The following is a description of a gene set: species: Homo sapiens Human Gene Set: MIR206 Genes predicted to be targets of miRBase v22 microRNA hsa-miR-206 in miRDB v6.0 with MirTarget v4 prediction scores > 80 (high confidence targets). from publication Chen Y, Wang X (PMID 31504780), and this is the list of marker genes: MEA1, HS3ST3B1, SH3TC2, BCL7A, CLOCK, SLC8A2, NETO2, KMT2E, PPIB, TRA2B, NFATC2, XPO6, KTN1, PLXNA4, CAAP1, SLC25A53 (solute carrier family 25 member 53), RNF138, ZBTB41, PCDHB13, TTC7B (NCBI Gene Id 145567), EIF1AX, FN1, FRS2, TNS3, ARCN1, MCTP1, JARID2, LRATD1, TMEM243, MAP4K2, DACH1, SLC25A36, TMSB4X, RNF38, CLTC, RIT2, PHIP, ZFP36L2, RNF145, ZNF326, HIGD1A, THBS1 (thrombospondin 1), RICTOR, PABPC1L2B, CBL, BSCL2, CPEB1, GPR6, ZNF280D, ZMAT3 (NCBI Gene Id 64393), STMN2, UST, LIPI, SRGAP2, HNRNPU, CD2AP, PCARE, HSP90B1, ZNF547, S100A7A, RTN4IP1, ARPC3, MMD, TNPO2, PICALM, WWC1, RAD54B, CAPRIN1, CCDC170, MBLAC2, TRAPPC3, TBX3, CDK14, INTS6, MTX1 (NCBI Gene Id 4580), SULF1, FUBP1, C2orf69, GOLPH3, ANP32E, METTL21A, TMCC1, G6PD, SLC25A22, MINDY2, PHF6, SEMA6D, ETS1, LASP1, GPR85, RFLNB, ADAM12, ARK2C, HMGN1, LAMP2, YWHAZ, ADAR, PDIK1L, NEXMIF, ARF3, ANKRD29, KCNMB2, RAB5A, SLC29A3, FNDC3B, KCTD10, DLG1, SEC23B (SEC23 homolog B, COPII coat complex component), NALF1, MMRN1, NINJ1, RARB, MIPOL1, THAP12, FAM91A1 (NCBI Gene Id 157769), KAT6A, INMT, NCL, FAIM, CAP1, FOXP1, SRSF1, SLC35B4, IGF1, FBXW7, GIT1, EEIG1, SOWAHC, GIPC2, RABGAP1L, GCH1 (NCBI Gene Id 93984), VAMP4, BSN, WBP1L, PDK3, ANXA4, SFRP1, PDCD10, OSBPL7, PDCD4, SPRED1, FUT3, WNK3, HP1BP3, MSANTD2, PEAK1, ASRGL1, PIRT, TRIM31, PRKCE, ADPGK (ADP dependent glucokinase), PBX1, SP2, WDR48 (WD repeat domain 48), RIMOC1, CCL2, BPNT1, FAM72A, EML3, CDKL5, MMD2, SEC22B, SLC37A3, TBX18, SNAI2, PAX3, SLC7A2, PTPN14, SLC25A30, HIPK3, ZEB2, GLCE, UBE2H, IFT52, CTTNBP2NL, MYOCD, MPP7, BCL11A, PDE12, ZNF24, TAGLN2, FAM72B, STARD7, SLC35B3, TSPAN4, NBEA, FBXL14, SEC63, DGKH, API5, CHSY1, CAVIN2, ZNF800, TBCK, ANXA2, FAM72C, TFE3, SERP1 (stress associated endoplasmic reticulum protein 1), RIMS4, MYLK, TOX3, NUP50, SATB1, FAM168A, NAB1, NFAT5, EBPL, MEOX2, HIVEP3, DDX55, HELZ2, TRPS1, KANK4, HACE1, SAMSN1, DCP2, GRK6, MAX, SLC39A9, ADGRA3, MEX3C, NT5C1B-RDH14, CNN3, CERS2, CEBPZ, POGK, ATF2, GPR137C, CREBL2, SMARCB1, CORO1C, TBC1D15, ARHGAP20, RBM27, ZNF250, ZBTB6, NOL4L, DRD1, USP33 (NCBI Gene Id 23032), EPHB1 (EPH receptor B1), KMT5B, EIF4E, PDE7A (phosphodiesterase 7A), SEC61A1, CREB5, KIF2A, LRCH1, TIMP3, NDRG3, PTPN1, MATR3, PLPPR4, NET1, CLCN3, KCNIP3, AP1B1, GCLC (NCBI Gene Id 2729), UBE4A, TPPP, EDN1, CCDC32, NEDD9, DDX5, STK39, STC2, BDNF, COL19A1, PRKACB, PREX1, FAM72D, PPP4R3B, NFATC3, BHLHE22, GPD2, MCHR1, FOSB, PAX7, CREM, MAL2, SMARCC1, GLCCI1, MAB21L1, KAT6B, GPR158, STAG2, ASXL3, YWHAQ, SLC35G1 (solute carrier family 35 member G1), KCNJ2, FBXO33, PTPRG, WDR1, LRRC8A, SLC38A3, CITED2, PRDM10, PFDN1, TPM4, AJUBA, ATG13, FLI1, TMEM135, THRB, AZIN1, E2F5, TAF1B, ZNF281, SMIM14, CCDC146, ARF4, MGAT4A, NXT2, SKIC8, SNX2, PIK3C2A, SRSF9, JOSD1, SLC8A1, ZBTB4 (NCBI Gene Id 57659), CWC15, GABRA3, ACER2, SPRN, KLF4 (KLF transcription factor 4), MON2, SAMD8, WIPF2, ATP6V1A, SRI, HYCC1, MECOM, ACTB, BTAF1, HACD3, PPP4R2, TWF1, NRP1, ASH2L, PHAX, SLC10A7, IMPACT, MAP4K3, MXD1, RGS7, ELF1, NCOA1, UTRN, MFSD14A, SYT1, UNC119B, CCSAP, INSM1, HMBOX1, SLC39A10, SUSD1, SCAF11, TRIM2, GNPDA2, UHMK1, AP1S1, AKAP11 (A-kinase anchoring protein 11), FNDC3A, CPED1, TMEM178A, TNKS2, SLC44A1, SLC25A25, PALS1, SOX9, HSPD1, SLC6A11, ZFP36L1, MET, GJA1, SS18, BACH2, IP6K2, AP1G1